Given this list of marker genes KCNK12, RYR3, BIN1, SLC9B1, CALHM4, REM1, NDUFS2, CACNG5, UBR3, ATP13A4, KCNMA1, BEST2, ATP5F1C (ATP synthase F1 subunit gamma), SLC25A4, SLC6A9, TPTE2, SLC31A2, WWP1, COX17, ATP5MC2, SLC39A7, GRXCR1 (glutaredoxin and cysteine rich domain containing 1), KCNIP1, KCNA10, OPRM1, TRPV6, UBASH3B, YWHAE, FXYD2, SLC25A27, PACC1, CLIC6, GRIA2, SLC6A20, FXYD6P3, CACNA1H, ATP1A2, SLC5A10, GRIN2D, ABCC4, ABCC5, TMEM63B, MT-ND2, ZACN, TCIRG1, SLC25A28, CHRNA6, ATP6V1C2, NDUFC1, KCNJ18, SLC39A11, TRPC5, SNTA1, KCNJ8, DPP10, SPG7, COX7A1, COX6B1 (NCBI Gene Id 1340), SLC30A7, FGF13, CATSPER2, KCNJ12, AFG3L2, FKBP1B, CNGA3, ATP6AP2, SLC26A6, PRKACA, NOL3, TMEM63A, ZDHHC13, TESC, CACNB3, TRPM2, GJC1, CLIC1, SLC30A8, WNK2, TTYH2, FAIM2, CXCL11, SLC4A7, TRPV1, SLC13A4, SLC6A1, SLC30A1, MT-ND6, CAB39, SFXN3, MIR328, NDUFB1, BEST3, SLC9A8, ATP6V1B2, ATP5F1A, KCNA2, SLC18A1, NPPA, CATSPER4, ATOX1, NDUFB8, KCNA7, PMPCB, CXCL9, GABRA5, CACNB2, ABCC2, PDE4B, LCN2, CHRND, ATP6V0E2, MT-ND1 (NCBI Gene Id 4535), CASQ2, SLC9A4, ATP1B1, ANO10, CLCN3, ATP7B, SCN3B, SLC9A3, KCNK15, NMUR2, DMD, ATP5F1E, KCNH3, CASQ1, CHRNA4, FASLG, RGS4, UCP1, LRRC38, CHRNA3, KCNK17, HEPH, ANO6, CACNA2D3, SLC8B1, CACNA1G, GPER1, GABRG3, SLC23A1, WNT3A, CACNB1, PKD1, NDUFV2, SLC1A2, KCNK6, TRPV5, KCNK2, SLC17A6, TTYH1, STIM1, ATP5MC3, NOX5, GPR89A, PIK3CG, UBQLN1, SLC6A19, CASR, CHP1, CCDC51, NIPSNAP2, SLC26A2, TMEM63C, PLCB3, AQP1, GABRR3, SCN7A, ANO3, KCNN4, ATP5MF, ATP7A, SLC1A3, NDUFS7, CAV1 (caveolin 1), SLC26A11, CHD7, GRIA4, SLC11A1, SCARA5, KCNQ1, HCN4, CALM3, SLC6A13, CCL3, LRRC8E, KCNK1, KCNMB4, CHRNB3, SLC1A4, ATP1A4, SNAP25, KCNE1, ANO4, TMC8, RANGRF, TMEM175, FMR1, ATP5F1EP2, TRPM5, ANK3, HCN1, CHRNA9, SLC12A3, CACNG8, ABCC10, GRIN3A, STAC, SCN4A, LRRC8B, NDUFA5, ATP5PF, NDUFB10, UQCRC1 (NCBI Gene Id 7384), CEMIP, STAC2, NDUFA12, HTR3A, PML, LRRC52, UQCRFS1P1, ATP13A5, GRIK1, PLCB4, TSPAN13, LRRC8A, ATP2A1, DMAC2L, MT-ND5, ITPR2, KCNS2, KEL, TCAF1, SLC41A1, TRPM1, ATP6V1E1, JPH2, ATP5MC1, TMSB4X, SLC22A1, ATP13A3, MIR21, PPP3CA, STEAP2 (NCBI Gene Id 50630), SLC13A3, SLC18B1, SLC25A25, CRHR1, SLC8A1, KCNS1, P2RX7, PTPN3, SLC47A1, KCNG3, ATP5PO, SLC17A7, CLIC4, CLCN6, CFTR, CNNM2, NOS1AP, TMEM94, SLC29A4, FXYD4, FXYD7, NIPAL1, TCN1, BSND, CCR5, MIR29B1, SCNN1D, OPRK1, SLC39A12, TMC3, NDUFV1, CNGA2, CACNA2D4, SFXN1, CHRNB1, CHRNA2, PKD1L1, AKAP6, NPSR1, SLC5A5, GABRG2, SLC39A6, CALHM3, JPH4, JPH1, COX5A, KCNAB1, SLC4A2, UQCR10, CACNG2, NDUFS6, RYR1, YWHAQ, COX4I1, OTOP1, LACRT, KCNJ1, CNGB3, ATP2C1, SLC2A9, UNC80, TMEM38B, GP9, ITGB3, SLC36A1, COX8A, HVCN1, KCNE3, NDUFB6, CALHM6, SLC9A5, P2RY6, ATP5F1D, KCNT1, ATP6V1G2, ASIC1, KCNJ13, GABRE (NCBI Gene Id 2564), RGS9 (NCBI Gene Id 8787), GABRQ, CNNM4, DCD, CYBB, CNGA1 (cyclic nucleotide gated channel subunit alpha 1), ATG5, CACNG3, KCNA6, MCUR1, PRNP, MIR212, ACTN2, GABRB1 (NCBI Gene Id 2560), APLNR, SLC39A2, SCN10A, KCNK5, PKD2L1, PLCB2, GABRA1, LCK, NDUFB5, KCNJ5, PKD2L2 (NCBI Gene Id 27039), STAC3, P2RX3, CACNA1F, NDUFB3, UCP2, JPH3, HTR3C, MCOLN2, GRIK5, TRPC1, KCNG1, TMC5, KCNK13, SLC6A2, ASIC3, TMEM38A (transmembrane protein 38A), DHRS7C, GP5, GABRA3 (NCBI Gene Id 2556), CHERP (NCBI Gene Id 10523), TMCO1, MT-ND3, ATP4A, CCL19 (NCBI Gene Id 6363), CLCN2, SLC30A10, SLC1A7, PKD1L3, VAMP2, HTT, SLC34A1, MIR24-1, KCNK4, MIR210, GLRB, SLC30A2, HTR2C, PRKCE, SLC38A2, KCNE2, CLCA4 (NCBI Gene Id 22802), KCNV2, CXCL10, TTYH3, TMEM37, GRIN1 (glutamate ionotropic receptor NMDA type subunit 1), CACNA1E, KCNIP3, PSEN1, SUMO1, SLC25A22, KCNMB2, ITPR3, SLC6A15, EDN1, CATSPER3 (cation channel sperm associated 3), SLC6A14, XCL1 (NCBI Gene Id 92337), APP, HTR2A, OCA2, KCNB1, GRIK2, HTR3B, KCNK9, MS4A1, SLC26A5, SLC19A1, BEST4, SLC39A4, CUL5, AKAP5, P2RX6, BHLHA15, CLCNKA, SLC13A2, KCNG2, SLC1A1, DRD1, LRRC26, KCNJ15, SLC38A4, KCNS3, SLC26A1, IL13, HAP1, LASP1, CHRNB4, NEDD4, SLC39A9, SLC12A5, NIPA2 (NIPA magnesium transporter 2), SFXN5, ATP6AP1, GRID1, HPN (NCBI Gene Id 3249), SLC26A7 (NCBI Gene Id 65015), PDPK1, G6PD, TCAF2, ANO5, SNCA, SLC4A5, SLC18A2, SLC17A3, SCN2B, F2R, CTNS, ATP6V0D2, SLC26A9, KCNC3, SLC13A1, CAPN3, COX5B, SEC61A1, ANO8, VDAC3, SLC11A2, TUSC3, NDUFS4, CACNG4, TPCN1, NALCN (NCBI Gene Id 93074), KCNH4, NDUFA2, SLC25A3, KCND1, NDUFB2, KCNQ3, SLC5A3, MIR448, KCNH5, SLC5A6, CHRNA5, ATP6V0B, ACTN4, MCU, SLC5A2, PPIF, SLC25A13, TRPM7, PHB2, MMGT1 (membrane magnesium transporter 1), GRIA3, CNGB1, GABRR1, ATP5ME, CBLIF, HTR3D, SLC8A2, KCNH2, GABRD, ATP1A1, KCNN2, ABCB7, KCNH7, NCS1, PLCG1, PRKD1, SLC9A1, ATP8A1, TLR9, ABCC8, MIR499A, MT-ATP8, BDKRB1, GSTO1, PIEZO1, PLCL1, CALHM2, KCNK7, ATP6V1B1, ATP5PD (ATP synthase peripheral stalk subunit d), KCNA3, MT-CYB, PLCL2, CX3CL1, KCNA4, SLC26A8, MIR30D, SLC39A14, CCL21, SLC48A1, PCSK9, TRPV2, SLC17A8, PPP3R2, SLC15A4, MICU2, NDUFA9, CACNA1S, DPP6, KCNG4, STING1, AKAP7, SLC24A4, KCNH8, NDUFA6, SLN, STIMATE, TRPM4, GPM6A, CHRNG, IFNG, PANX1, SLC9C1, ITPR1, CLDN4, SLC8A3, CALHM5, SLC12A7, CLCC1 (chloride channel CLIC like 1), ATP6V0A2, LARGE1, SLC5A9, UTRN, PDE4D, SFXN4, TMC6, EDNRA, SLC6A7, ATP2B4, KCNJ6 (potassium inwardly rectifying channel subfamily J member 6), SCNN1A, ATP2C2, SPHK2, CLDN16, GABRB2, CALM1, MCUB, LYN, VDAC1, SLC24A2, SCNN1G, SRI, PTPRC, GRP, GHITM, PLN, MIR133A1, TPCN2, PLCB1, MIR103A1, SCN2A, KCNC1, TRPC4AP, WNK3, SFXN2, SLC9A9, CYBA, CRBN, KCNU1, SLC6A11, KCNJ2, MT-ND4, KCNK18, DRD2, KCNA1, MIR200C, GPR35, TRPV4, ORAI2 (NCBI Gene Id 84917), MT-CO1, ATP6V0D1, CD63, LIME1, FXYD6, MIR93, TRPM3, ATP10D, MIR26A1, NDUFA7, CD4, NDUFB4, GLRA2, CLCN7, AQP6, CAMK2D, CLDN17, BPIFA1, GRINA, SLC35G1, COX7A2L, EDNRB, CACHD1, SLC17A5, GRIK4, ROMO1, KCNT2, SLC25A23, SCN1A, WWP2, SLC47A2, KCNV1, CHRNA10, HTR2B, ASPH, SESTD1, SHROOM2, TRDN, KCNK16, SLC17A4, RYR2, SLC4A1, ATP11C, PLCG2, SLC38A1, SLC25A14, NDUFA10, KCNJ16, SLC5A1, GJA1, GABRG1, SLC20A2, TRPC4, KCNIP4, ATP6V1G1, TGFB1, SCN4B, SLC9A7, SLC4A8, ATP1B2, SLC12A4, KCNH1, FHL1, TMEM120A, SLC25A18, CYC1, PIEZO2, SHOC2, SCN1B, CNGA4 (NCBI Gene Id 338753), LRRC8C, EDN3, ANO9, SLC30A6, CLCN4, SURF1, TMEM163, SLC9B2, OXSR1, ATP6V1F, CCR7, MFSD8, KCNRG, CACNA1A, ANO2, METTL21C, HCN2, SLC4A3, ATPSCKMT, NDUFB7, SLC46A1, PPP3CC, CHRNE, SLC6A8, SLC4A11, GABRA6, SLC32A1, ATP13A1 (ATPase 13A1), SLC39A1, CHRNB2, P2RX5, MTCO2P12, ATP6V1A, GRIN2B, PSEN2, IBTK, CTSS (NCBI Gene Id 50653), MIR192, FLNA, SCN11A, ORAI3, LETM1, KCNC2, SLC41A2, GLRA3, SLC15A2, TRPC7, ADCYAP1R1, SLC6A17, ATP6V1E2, NDUFA1, GNB5 (NCBI Gene Id 82962), KCNK3, HPCA (hippocalcin), MCOLN1, ATP1A3, MT-CO3, KCNIP2, SLC18A3, NDUFV3, TOR2A, CRACR2A, TPTE, PKD2, SLC38A5, CLCA2, ANO7, ATP2B2, THY1, KCNH6, NDUFA4, SCN9A, KCNAB2 (NCBI Gene Id 8514), P2RX1, PKDREJ, COX7B, KCNA5, CLIC5, KCNMB3, TMC4, UCP3, NDUFB9, DLG1, KCND2, ITGAV, F2RL3, SLC39A13, KCNJ14, AHNAK, STRIT1, ISCU, SCN5A, GRM6, BCL2, NDUFS1, LETM2, ATP6V0A1, FGF2 (fibroblast growth factor 2), TMC2, ATP5MGL, KCNJ10, GRID2, CALHM1 (calcium homeostasis modulator 1), ABCC9, TMBIM4, CACNG6, CXCR3 (C-X-C motif chemokine receptor 3), SLC9A2, SLC25A37, ATP8B1, GRIN3B (NCBI Gene Id 116444), SLC25A5, MAIP1, MIR1-1, TMCO3, SLC26A10P, SLC34A3, BEST1, SLC41A3, NNT, ABCC1, CHRNA7, SLC30A4, TRPM6, ATP6V0E1, ATP6V1H, SLC26A4, KCNJ4, SLC30A3, ERO1A, GAS6, KCNE5, KCNB2, ATP12A, STIM2, OSR1, KCNMB1, KCNQ2, PLCE1, UQCRH, PLCH1, MICU3, KCNN1, NDUFS8, TRPC6, TMEM165, FXYD3, FXYD5, ATP2A3, ATP6V1C1, PPP3R1, SLC30A5, CCT8L2, ATP2A2, EPO, ABCB6, TRPV3, SLC39A8, CACNB4, SELENON, PANX3, SCN3A, KCND3, SLC30A9, ABL1, TMEM109, SLC12A9, CLIC3, CLIC2, KCNJ11, ATP4B, GRIN2C, ATP10A, AP3D1, MT-CO2, GABRP, CLCN5, NALF1, SLC12A6, ATP6V1G3, MICU1, SLC24A5, DDIT3, DIAPH1, SLC6A12, SLC9A6, GRIA1, ASIC2, PTK2B, PTPN6, SLC36A2, SLC12A1, OTOP2, SLC16A1, KCNF1, CAV3, APOL1, KCNK10, PKD1L2, SLC17A2, UQCRFS1, CD19, TRPC3, CHRNA1, STK39, AMIGO1, TMEM150C, MRS2, ABCC3, LRRC8D, NDUFS3 (NADH:ubiquinone oxidoreductase core subunit S3), OTOP3, ATP2B1, SLC26A3, ATP5MG, CLCA1, MT-ATP6, GRIK3, XCR1, PANX2, NIPAL3, ANK2, KCNQ5, PLA2G1B, NDUFA3, TCN2 (transcobalamin 2), NIPAL2, SLC34A2, HTR3E, MMP9, COMMD1, WNK1, SLC5A11, SLC25A12, NDUFA8, CACNA1B, SLC6A6, SLC39A5, SLC12A2, CACNA1D, KCNC4, NDUFS5, HCN3, FXYD1, FGF12, CALCA, SLC6A4, CLCNKB, CACNG7, SCNN1B, TRPM8, HAMP, KCNQ4, GALR2, SLC15A3, ATP8B2, GABRB3, SLC2A10, HSPA9, ATP6V0A4, GJD3, F2, P2RX4, MIR208B, MT-ND4L, ATP1B3, FYN, ABCB8, SLC6A18, P2RX2, SLC4A9, VDAC2, SLMAP, SLC24A1, MIR208A, CBARP, ATP6V1D, CALM2, GABRA4, GP1BB, CACNA1I, SLC5A4, CACNA1C, ATP5PB, PLCH2, ASIC4, ANXA6, NEDD4L, CACNA2D2, SMDT1, STOM, SLC15A1, VMP1, SLC6A5, SLC39A3, MCOLN3, NTSR1, ATP5F1B, TRPA1, FKBP1A, SLC6A3, CACNG1, MAGT1, CORO1A, CATSPER1, ORAI1, ATP11B, RNASEK, SLC4A4, BAX, BAK1, TMBIM1 (transmembrane BAX inhibitor motif containing 1), GABRR2, KCNE4, PLP2, SLC12A8, NIPAL4, SLC4A10, GNB2, HRC, SLC13A5, SLC17A1, ABCC11, SLC46A3, SLC40A1 (NCBI Gene Id 56414), PPP3CB, NOS1, ATP13A2, CHRFAM7A, CACNA2D1 (NCBI Gene Id 781), TMC1, GAL, GPR89B, WNK4, SLC28A3, SLC24A3 (NCBI Gene Id 96617), GP1BA, GABRA2, GRIN2A, SCN8A, SLC31A1, ATP2B3, KCNJ3, NDUFC2, ABCC6, GSTM2, GOPC, NIPA1, SLC9C2, ASIC5, KCNAB3, SLC39A10, TMC7, NGF, SLC36A3, GLRA1, SLC20A1, SLC6A16, TMBIM6, CLCN1, S100A6, AGT, ATP6V0C, ANO1, LRRC55, SLC9B1P1 (solute carrier family 9 member B1 pseudogene 1), KCNJ9 (NCBI Gene Id 7820), KCNN3, NALF2, here is a description of the gene set: species: Homo sapiens Human Gene Set: GOBP_MONOATOMIC_ION_TRANSMEMBRANE_TRANSPORT A process in which a monoatomic ion is transported across a membrane. Monatomic ions (also called simple ions) are ions consisting of exactly one atom.